Given this list of marker genes Zfp512b, Cep135 (centrosomal protein 135), Galnt7, Med13, Eri2, Hoxa5, Slc9a6, Arid3a, Ecm2, Zfyve26, D630045J12Rik, Sall4, Trim41, Zswim5, Cldn12, Zfp354a, Ptchd4, Adamts8, Ints6l, Trhde, Hoxa9, Hapln1, Adrb2, Aptx (NCBI Gene Id 66408), Arl6ip6 (NCBI Gene Id 80483), Wnt9a, Lrrtm3, Cyp2b23, Acvr1c, Xpo7, Rufy3, Fam78a, Hoxc8, Hoxb7, Rpgrip1l, Smad4, Igf1r, Cysltr1, Uqcrb, Nme6, Zbtb26, Pcgf3, Utrn, Fign, Ugt2b37, E2f5, Ptafr, Cd46, Stk40, Lrrc75b, Ppp1r7, Skint3, Znrf3, Slc26a3, Atp8b4, Fignl2, Gata6, Sgo2a, Adrb3, 2310022A10Rik, Dnaaf6rt, Tsc22d3, Il2rg, Smad6, Ntrk2, Masp1, Cpeb3, Rgs16, Sftpa1, Svil, Sh3gl2, Hand1, Rnf38, Atp8b2, Mapk6, Pbx1, Klhl31 (NCBI Gene Id 320711), Trim71, Gatm, Snn, Slc6a4, Slc5a1, Prpf38b, Cercam, here is a description of the gene set: Genes predicted to be targets of miRBase v22 microRNA mmu_miR_1839_5p in miRDB v6.0 with MirTarget v4 prediction scores > 80 (high confidence targets). Mouse Gene Set: MIR_1839_5P studied in species Mus musculus from publication Chen Y, Wang X (PMID 31504780)